The following is a description of a gene set: electronically inferred by orthology from the curated human pathway studied in species Mus musculus Reactome Pathway: RUNX1 regulates transcription of genes involved in differentiation of keratinocytes part of: Transcriptional regulation by RUNX1 This event has been computationally inferred from an event that has been demonstrated in another species.<p>The inference is based on the homology mapping from PANTHER. Briefly, reactions for which all involved PhysicalEntities (in input, output and catalyst) have a mapped orthologue/paralogue (for complexes at least 75% of components must have a mapping) are inferred to the other species., and this is the list of marker genes: Serpinb13 (NCBI Gene Id 241196)